Given this list of marker genes CLP1, MTHFD1, GTF2I, NSUN2, IDUA, CTBP1, LOX, NCAPG2, COL18A1, GBA1, FIBP, MORC2, ABCD1, EBF3, LIMK1, MYCN, NEK9, ACTB, RPL10, MTHFR, SLX4, MAD2L2, RMRP, PDCD10, KCNH1, LIN28B, SMAD2, MBTPS2, HNRNPK, EP300, COMT (catechol-O-methyltransferase), COLEC11 (NCBI Gene Id 78989), NEPRO, MYLK, NFIA, BUD23, NEFL, EXT1, SPG11, TBL2 (NCBI Gene Id 27203), FANCI, POLA1, FGFRL1, CCND1, STX1A, MASP1, MTR, FBN1, THSD4, ARVCF, KIF1B, FKBP6, VPS37D, DKK1, GNPTAB, JMJD1C, CCNQ, KPNA3, TRAF7, FBLN1, HBB, CCT5, GP1BB, NF1, RAD51, SETD2, HRAS, CUL7, NRAS, ATXN3, PLEC, SOX5, ALK, PHGDH, PUF60, RFWD3 (ring finger and WD repeat domain 3), RAF1, SETX (senataxin, NCBI Gene Id 85506), COMP, GLB1, BRCA2, WBP11, COG4, PHEX, FANCE, PHOX2B, FLI1, FOXE3, DDHD2, PLP1, BRIP1, BICD2, SMARCB1, MEOX1, RASA1, KDM1A (NCBI Gene Id 23028), MESP2, ZEB2, TRPV4, DARS1, ATXN2, LEMD3, UBE2T, NMNAT1, DACT1, TGFB2, FOXC2, RORA, RAB23, ARSB, NAXE, PIK3CA, PRKG1, BRCA1, SYK, RECQL4, XRCC2, LMO1, SCARB2, CLIP2, CYP27A1, TWNK, FBXO11, CDK13, EFEMP2, HIRA, CYP7B1, FANCA, FXN, GALNS, RUNX2, ARID1B, FANCM, LIG4, TGFB3, NCF1, MMACHC, HAAO, MEG3, DLL4, ACTA2, B3GALT6, COL2A1, MTRR, NOTCH3, MFAP5, ARSL, ACVRL1, PAX3, IDS, SPTSSA, ARPC4, FOXF1, EXT2, B2M, FANCB, BMP2, RNASEH1, MYH11, DNAJC3, MINPP1, PI4KA, SPARC, BTD, HACE1, TGFBR2, DNAJC30, NELFA, VANGL1, LYST, CCBE1, FA2H, LMX1B, DDR2, DNA2, TRIM36 (NCBI Gene Id 55521), ABCA1, KANSL1, FOXE1, TLR7 (NCBI Gene Id 51284), FANCD2, IKBKG, NOTCH2NLC, CPLX1, BMS1, ENG, IL11RA, CREBBP, DARS2, RAD51C, DLK1, WASHC5, GLRX5, CCL2, SLC33A1, SCAF4, COLEC10, FLNB, KIF22, MYH3, TBX6, NOTCH2, TBXT, SALL1, SMAD3, SNRPB, GFAP, HNRNPH1, TBC1D24, GDF6, RBM8A, RAI1, ZIC1, FANCL, RFC2, METTL27, SOX9, MNX1, GDF3, UBAP1, POLR1A, KRIT1, NSD2, PRPS1, PSAT1, MAT2A, B3GLCT, REPS1, UFD1, NFIX, PIGG, GTF2IRD1, LETM1, TRAPPC14, RTL1, FANCG, RTN2, SH2B1, DLL3, TMEM270, TNXB, VHL, EXTL3, APC, ATXN1, AMER1, SEC24C, UBA2, SALL4, FANCC, PRKAR1B, ACY1, HEY2, CHN1, PNPLA6, FLVCR1, GNAS, MAN2B1, PTPN11, SMAD4, SLC26A2, LZTR1, LFNG, TDP1, BRAF, TBX1, ERCC4, GTF2IRD2 (NCBI Gene Id 84163), GCLC, TGFBR1, GJB2 (NCBI Gene Id 2706), PTDSS1, PORCN, ALDH18A1, RIPPLY2, EFEMP1, ATP6V1B2, ZFTA, MAFB, B4GAT1, SLC25A19, POLG, HMGA2, CHRNG, PALB2, RREB1, MAP3K7, IRF6, RPS19, CCM2, ELN (elastin), MFN2, HES7, SPG7, EIF4H, LMNB1, COQ6, CTNNB1, AKT1 (NCBI Gene Id 207), ZMYM2, PRMT7, BAZ1B, GJB1, VANGL2, FANCF, FUZ (fuzzy planar cell polarity protein), RRM2B, PTCH1, HABP2, SRRM2, NF2, SUPT16H, ITGB4, HMX1, FLNA, here is a description of the gene set: A structural abnormality of the spinal cord (myelon). studied in species Homo sapiens Abnormal spinal cord morphology Human Gene Set: HP_ABNORMAL_SPINAL_CORD_MORPHOLOGY